Given this list of marker genes DNAH7, DNAI2, DNAI1, CFAP300, CCDC39, TTC12, DNAAF3, CCDC103, CFAP298, SPAG1 (NCBI Gene Id 6674), ODAD3, DNAAF1, DNAAF11, DNAAF5, DNAL1, ZMYND10 (zinc finger MYND-type containing 10, NCBI Gene Id 51364), DNAH9, ODAD1, NME8, here is a description of the gene set: An anomaly of the dynein arms of motile cilia. This feature is usually appreciated by electron microscopy. studied in species Homo sapiens Human Gene Set: HP_DYNEIN_ARM_DEFECT_OF_RESPIRATORY_MOTILE_CILIA Dynein arm defect of respiratory motile cilia